The following is a description of a gene set: Proximal muscle weakness in upper limbs A lack of strength of the proximal muscles of the arms. Human Gene Set: HP_PROXIMAL_MUSCLE_WEAKNESS_IN_UPPER_LIMBS studied in species Homo sapiens, and this is the list of marker genes: OBSCN, TRPV4, CHRNB1, POMT1, SMPX, CHRNA1, LAMA2, MT-CO3, COL13A1, PPOX, DOK7, NEFL, LDB3, AGRN, LRP12, SNUPN, MFN2, FBXO38, MORC2, LPIN1, CHRND, SPG11, TCAP, VWA1, ANO5, JAG2, RILPL1, HMBS, RAPSN, FHL1, GIPC1, DYSF, CHCHD10 (coiled-coil-helix-coiled-coil-helix domain containing 10), KY, SYNE2, MTMR14, LRP4, LMNA, GDAP1, EMD, VCP, ADSS1, HMGCR, RYR1, AK9, CRPPA, MT-CO1, LIPE, SCN4A, TMEM43, SYNE1, SBF2, DNM2, MUSK, SLC12A6, CHRNE, MYF6, BIN1, NOTCH2NLC, CPOX, ANXA11, JAG1, COQ7, GMPPB